Given this list of marker genes Rras2, Grin1, Lrp1, Ptprz1, Tiam1, Fubp1, here is a description of the gene set: Any process that activates or increases the frequency, rate or extent of Schwann cell migration. species: Mus musculus Mouse Gene Set: GOBP_POSITIVE_REGULATION_OF_SCHWANN_CELL_MIGRATION